Given this list of marker genes ENSA, WWP2, CAV1, NEDD4L, NEDD4, RASA1, CAV3 (caveolin 3), OXSR1, STK39, KCNE4, KCNK2, here is a description of the gene set: Human Gene Set: GOMF_POTASSIUM_CHANNEL_INHIBITOR_ACTIVITY species: Homo sapiens Binds to and stops, prevents, or reduces the activity of a potassium channel.